The following is a description of a gene set: studied in species Homo sapiens A molecular adaptor that recognizes and binds a target protein containing a ubiquitin-like modification and that brings the target protein into contact with another protein to allow those proteins to function in a coordinated way. Human Gene Set: GOMF_UBIQUITIN_LIKE_PROTEIN_READER_ACTIVITY, and this is the list of marker genes: BARD1, SAYSD1, DNAJC2, STK38, JARID2, TP53BP1, FAAP20 (FA core complex associated protein 20), PEX1, DNAJB2, USP15, FAN1 (NCBI Gene Id 22909), SQSTM1, CCDC38, BRCA1, ANKRD13B, PEX6, VCP, RNF169, ANKRD13A, ANKRD13D, DDRGK1, UIMC1